The following is a description of a gene set: Catalysis of the reaction: ATP + a protein = ADP + a phosphoprotein. This reaction requires diacylglycerol. species: Homo sapiens Human Gene Set: GOMF_DIACYLGLYCEROL_DEPENDENT_SERINE_THREONINE_KINASE_ACTIVITY, and this is the list of marker genes: PKN3, PRKCG, PRKCI (protein kinase C iota), HSPB1, YWHAG, DGKQ, SMG1, SFN, PRKCA, PRKCQ, PRKCH, PRKCB, PRKD3, PRKCZ, PKN2, PRKD2, PKN1, PRKCE, PRKD1, PRKCD